Given this list of marker genes Ddit3, Scrib, Cenpi, Nek1, Haus3, Cdk18, Cep44, Tunar (NCBI Gene Id 69952), Mns1, Trim21, Cenph, Nbn, Vps72, Sgo2a, Ccdc15, Usp44, Camk2d (NCBI Gene Id 77170), Ppm1g, Foxe3, Mdm4, Zfp830, Ppp2r1a, Gadd45b, Ufl1, Ect2, Rpl10l, H2-M3, Senp2, Prkce, Morc2b, Jund, Prkaca, Ednra, Pole (polymerase (DNA directed), epsilon), Gigyf2 (NCBI Gene Id 98689), Mtcl1, Map3k7, Esco2, Ttk, Tuba3a, Anln, Six3, Gm21294, Gm5934, Myog (myogenin), Trp53, Rab11a, Msh4, Akt1, Exoc7, Mrgprb1 (MAS-related GPR, member B1), Nr4a1, Dynlt3, Haspin, Hmga2, Septin3, Cc2d1a, Kif14, Smc2, Stard9, Rrs1, Baz1b, Plrg1 (NCBI Gene Id 99527), Usp9x, Mnd1, Fbxo43, Dna2, Hsf2bp, Brd8, Bop1, Nrde2, Ccnd1, Rprd1b, Taf6, Prmt2, Aatf, Cdkn1c, Exoc6, Jade3, Taok1, Mir744, Zfp503, Btbd18, Rad54l, Katnb1, Bmp7, Ino80d, Phf10, Rhoc (NCBI Gene Id 99594), Lzts2, Mapre1, Egfr, Ywhae, Bmp4, Wee2, Pcnt, Dctn2, Cenpt, Mir124a-3, Mad2l1bp, Brdt, Ints7, Iqgap1, Pms2, D1Pas1, Hes1, Fbxo7, Tcf3, Anapc2, Gm29866, H1f8, Apex1, Prr11, Brd7, Zbed3, Svil, Ets1, Ncapg2, Rcc2, Usp8, Kifc5b, Zzz3, Hexim2, Ccpg1, Eif2ak4, Lsm14b, Nf2, Prap1, Prpf19, Dgkz, Nde1, Htt, Vash1, Pmf1, Myo19, Eme1, Ehmt2, Knstrn, Zwint, Mir26a-2, Hormad1, Npat, M1ap, Lfng (LFNG O-fucosylpeptide 3-beta-N-acetylglucosaminyltransferase), Zfp365, Son, Tubgcp4, Gm21760, Cenpk, Gm1993, Per2, Cep250, Gper1, Prox1, Rad51c, Cetn2, Hfm1 (NCBI Gene Id 381663), Hmgb1, Nek9, Cdk3, Bex6, Foxa1, Meig1, Fosl1, Zic1, Usp2, Ccdc42, Pdgfrb, Chmp1b2, Champ1, Dscc1, Trp63, Tpra1, Crebbp, 1700028K03Rik, Tmem67, Khdrbs1, Trim75, Celf1, Cenpf, Haus2, Pnpt1, Stag1, Mcmbp, Pkp4, Kif20b (kinesin family member 20B), Ing5, Ins1, Cgref1, Gja1, Calm1, Ago4, Cep76, Cenpo, Shoc1, Kctd19, Xlr4b, Rpl23, Junb, Nuggc, Map9, Madd, Birc6, Asns, Gpr15lg, Dlg1, Dync1h1, Dr1, Rec114, Luzp1, Espl1, Cdc27, Nudt6, Cks1b, Cdc16, Cep85, Med1, Haus8, Calm3, Ube2a, Plk1, Cdk5rap1, Kifc1, Nubp1, Insm1, Il1b, Nup43, Pik3c3, Numa1, Cdc5lrt7, Pcna, Nanos3, Septin6, Zfp36l1, Nup37, Fzd9, Epgn, Cep131, Gm1140, Ccl12, Xrn1, Ccnb2, Jade1, Angel2, Pmp22, Cul9, Cdc42, Gm28576, Anapc7, Septin5, Dstn, Ccnd2, Aunip, Cul4a, Mtbp, Ccny, Birc7, Mir124a-1, Setdb2, Tmsb4x, Appl1, Nek7, E2f8, Brinp2, Top2a, Xlr5b, Gm20824, Psma8, Gli1, Kcnn4, Cdc5lrt4, Pkmyt1, Chek1 (NCBI Gene Id 97555), Fancm, Tpx2, Ckap2, Spin1, Myocd, Rbm7, Ccnjl, Wdhd1, Trim36, Foxg1, Bmp2, Ppp2r1b, Rbl1, Cdk8, Septin7, Ppp2r3d, Sdccag8, Slf1, Mzt1, Camk2g, Mcm6, Mir124a-2, Rrm2b, Gm20820, Syde1, Cdkn1a, Smoc2, Crnn, Zscan21, Ube2l3, Gins3, Gm5169, Gm5168, Actl6b, Myh10, Gen1, Misp, Azin1, Klf11, Cebpa, Gm28102, Cul4b, Rptor, Stxbp4, Chmp6, Setd2, Akap8, Inip, Mrnip, Sh3glb1, Klhl18 (kelch-like 18), Tnks, Eme2, Ercc1, Tesmin (NCBI Gene Id 17771), Hpgd, Ino80b, Zic3, Spo11, Tiprl (TIP41, TOR signalling pathway regulator-like (S. cerevisiae)), Ube2i, Ctdsp1, Pard6a, Bccip, Camk2b, Yeats2 (YEATS domain containing 2), Gipc1, Usp29, Atm, Ercc4 (NCBI Gene Id 50505), Gm6121, Mdc1, Tcf19, 1700013H16Rik, Ccng1, Trrap, Cdk15, Haus5, Kif4, Slx4, Cenpa, Mta3, Zfp318, Csnk2a1, Stambp, Smarcad1, Arid2, Ush1c, Nr4a3, Chmp3, Cdc5lrt6, Cdca5 (cell division cycle associated 5), Mcrs1, Mir26a-1, Nup62, Calm2, Llgl2, Unc119, Ezh2, Ofd1, Prpf40a, Nop53, Nr2f2, Afg2b, Evi2b (ecotropic viral integration site 2b), Bmyc, Upf1, Cks1brt, Mrgbp, Ppm1d, Pttg1, Foxk1, Ncapg, Rps3, Brox, Mbtd1, Hjurp, Tas2r102, Eif4g1, Nasp, Sfrp1 (secreted frizzled-related protein 1), Nr2e1, Mybl1, Anxa1, Ube2s, Exoc4, Ccdc61, Ska1, Ccnb1, Akap8l, Azi2, Phf13, Ptprv, Mlf1, Chmp7, Xlr5a, Rprm, Dot1l, Brca1 (NCBI Gene Id 12189), Kdm8, Setmar, Sycp3 (synaptonemal complex protein 3), Fgf10, Rhou, Ccnb1-ps, Tert (telomerase reverse transcriptase), Mdm1, Ctdsp2, Ankrd53 (ankyrin repeat domain 53), Drd3, Stox1, Ankrd17, Septin2, Tubal3, Kiz, Wnk1, Tubb3, Ube2srt, Hyal1, Ckap5, Usp50, Pabir1, Stag2, Cdc26, Rad23a, Smarcc1, Ccno, Cdc5lrt1, Dynlt1b, Pdcd6ip, Utp14b, Bcl2l1, Yy1, Rtkn, Zfyve26, Ptprk, Septin14, Pds5a, Arid1a, Spc24, Fhad1, Psmd10, Kif20a, Lig1, Exoc6b, Ptprc, Ensa, Tuba1b, Bag6, Crocc, Abraxas2, Pkn2, Gm20870, Gm5935, Cdkl1, Dmrtc2, Sox2, Ppp2ca, Ppp2r5c, Tubb4b, Tbx1, Cenpu, Pbx1, Btrc, Tti1, Hepacam, Ccdc57, Xpo1, Uba3, Grb14, Chmp4c, Pnma5, Pogz, Clspn, Dtx3l, Sox9, Rec8, Phgdh, Hacd1, Wfs1, Sirt7 (sirtuin 7), Insm2, Kif18b, Rad17, Actr3, Cep120, Ilkap, Usp33, Ilk, Tex11, Brinp1, Gm2030, Rpl17, Cav2, Xlr5c, Wnt10b, Chmp5, Bin1, Brme1, Aspm, Mapk8, Ppp2r5d, Fsd1, Chmp4b (NCBI Gene Id 96954), Mok, Tsc22d2, Bax, Poc5, Bcr, Tfap4, Aicda, Pias1 (protein inhibitor of activated STAT 1), Xlr4a (NCBI Gene Id 630479), Rhno1, Slx, Vps4a, Nek6, Pafah1b1, Fbxo5, Inppl1, Ctdp1, Parp9, Znhit1, D7Ertd443e, Nfia, Fam83d, Ccar2, Nherf1, Stx2, Lipa, Stk38, Naa50, Rpa2, Tbce, Rnf2, Gm773, Tubb2a, Rps6kb1, Dlgap5, Igf2, Spdya, Cenpm, Yeats4, Zfp36l2, Cep192, Ccnh, Riok2, Tbcd, Arhgap33os, Tsc1, Piwil2, Dmrt1, Cdk13, Ctcf, Gem, Smarca2, Srpk2, Myh9, Aaas, Terb2, Pkhd1, Mau2, Ppp2r2d, Ciao2b, Stag3, Tex12, Pim2, Septin10, Map1s, Wdr90, Septin9, Efhc1, Adcyap1, Ncaph2, Ticrr, Sphk1, Klhl21, Nuf2, Fam110a, Boll, Ccne1, Cenpx, Hdac8, Lats2, Mbtps2, Zfy2, Itgb3bp, Mcm3, Rps6ka2, Smc6 (NCBI Gene Id 67241), Tom1l1, Cdc5lrt10, Sass6, Alox8, Tle6 (NCBI Gene Id 69799), Brcc3dc, Pds5b, Morf4l1, Mis12, Ankle2, 4933427D14Rik (RIKEN cDNA 4933427D14 gene), Obsl1, Gmnc, Fgf8, Sdcbp, Kank2, Prdm11, Cdk16, Birc3, Hus1, Zfp369, Cntln, Zw10, Xlr3a, Mapk12, Nek11, Btc, Nup214, Ccp110, Septin8, Nppc, Flna, Rmi2, Cdc23, Pibf1, H2ax, Tppp, Rad18, Tm4sf5, Sra1, Rnaseh2b, Gm21117, Edn3, Tubb2b, Nek2, Cdk6, Cdkl4, Suv39h1, Abcb1b, Nupr1, Septin12, Rps27l, Slxl1, Fbxl7, Ska2, Prpf4b, Ccnf, Dtl, Arl8b, Sgsm3, Cdc14a (CDC14 cell division cycle 14A), Gm4297, Incenp, Abcb1a, Lgmn, Il1a, Il10, Gm2012, E2f6, Bid, Igf1, Anapc1, Pten, Hspa1a, Gm7958, Btg3, Spry2, Slc26a8, Haus7, Mapk1ip1, Ereg, Pstpip1, Prc1, Ripor2 (RHO family interacting cell polarization regulator 2), Bcl2, Tal1, Arhgef2, Wiz, Ccna2, Cops5, Trappc12, Bub1, Tpd52l1, Ptgs2, Kash5, Sirt2, Ddx4, Nudc, Pagr1a, Parp3, E2f1, Rrm2, Clgn, Xiap, 4930447C04Rik, 3830403N18Rik, Nlrp5, Pld6, Rab11fip3, Brcc3 (NCBI Gene Id 210766), Uvrag, Pcm1, Pggt1b, Sgo1, Spry1, Cltc, Tlk1, Iqgap2, Kat2b, Cdk4, Aurkc, Golga2, Gpr3, Atxn10, Plk4, Osm, Top3a, Gpsm1, Fzr1, Arhgef10, Axin2, Cdk5rap2, Smarcd1, Smpd3, Uhrf1, Stil, AY074887, Diaph3, Vps4b, Camk2a, Errfi1, Rad51d, Dact1, Gm29276, Dctn6, Bcl2l11 (NCBI Gene Id 76339), Iqgap3, Slc25a31, Cdkn1b, Kat7, Dctn3, Ovol1, Gnb1l, Cdc45, Ubb, Tas2r121, Mybl2, Trip13, Eif4e (NCBI Gene Id 668879), Spart, Ubr2, Chmp2b, Pola1, Tubd1, Rhob, Hoxa13 (NCBI Gene Id 15398), Git1, Chmp1b, Tex15, Ube2b, Ndc80, Trim71, Cdc6 (cell division cycle 6), Ncapd3, Mir26b, Ezr, Psme1, Bora, Lrp6, E2f4, Cdk11b, Dab2ip, Bcl7c (NCBI Gene Id 233901), Mnat1, Nsl1, Fbxw11, Bnip2, Brd4, Tas1r2, Mei4, E4f1, Stk11, Xlr3c (NCBI Gene Id 768249), Adam17, Kif23, Rps15a, Birc2, Mtmr4, Ccni, Zfyve19, Meioc, Hspa2, Fbxw7, Btn2a2, Sfn, Sirt1, Meikin, Cenpe, Ptpn11, Tubb6, Poc1a, Ccnq, Prkca, Psmd13, Calr, Zfp541, Nfix, Anxa11, Plk2, Rad50, Cntrob, Id2, Skil, Cdca8, Pebp1, Cdkl3, Anapc15, Usp16, Hnrnpu, Dicer1, Mki67, Plk5, Rnf212b, Exoc5, Ctbp1, Ccnl1, Ciao2a, Tubg2, Slc16a1, Mael, Ska3, Cdc7, Tuba1a, Dnm2, Rpa1, Tex14, Fgf2, Chordc1, Limk2, Cdca2, Rgcc, Ino80e, E2f2, Esco1, Pdpn, Smc1b, Cdc73, Gm28919 (predicted gene 28919), Exoc8, Nsun2, Pum1, Tubb5, Fhl1, Pcid2, Ing2, Rttn, Cenatac, Tex19.2, Rxfp3, Ecd, Msh2, Cables2, Cep63, Egf, Brsk1 (BR serine/threonine kinase 1), Cdk17, Cdk9, Prdm5, Cry1, Mcidas, Birc5, Anapc5, Atr, Recql4 (NCBI Gene Id 79456), Trp53i13, Snx33, Tubb4a, Bak1, Usp19, Top3b, Taok3, Ccnd3, Ccng2, Orc1, Ndc1, Nanos2, Ppp3ca, Zbtb17, Exd1, Dpf3, Cpsf3, Mdm2, Ddr2, Ccnb3, Adamts1, Fem1b, Nme6, Tubgcp2, Hdac3, Smarcb1, Cdk2, Pard6b, Paf1, Sin3a, Mapk15, Paxip1, Tom1l2, Exoc2, Ran, Dbf4, Tgfb2, Mbtps1, Cdk5r1, Prkdc, Llgl1, Prickle1, Cks2, Pkd1, Fgfr3, Gas2, Pax6, Mtcl2, Bmal1, Filip1l, Gm29554, Csnk1d, Rmi1, Spice1, Aven, Eml3, Tacc1, Smarcc2, Lif, Ier3, Stmn1, Npm2, Rock1, Chmp1a, Pou4f1, Nabp2, Rad21, Ctnnb1, Sun1, Tbrg1, Shb, Rnf167, Rps6, Fbxo30, Smarca4, Mepce, Pkia, Casp3, Dapk3 (death-associated protein kinase 3), Cacnb4, Cdt1, Cspp1, Hspa8, Kat2a, Cul7, Gata4, Romo1, Mus81, Epc2, Mcm5, Nek10, Cep152, Actr8, Cts7, Ttl (NCBI Gene Id 99091), Npm1, Mcm2, Cep295nl, Enkd1, Tubgcp5, Pclaf, Slf2, Mfn2, Ntmt1, Clock, Snx9, Sin3b, Tdrd12, Kif2a, Cdk14, Fkbp6, Ubd, Tsg101, Msx1, Sik1, Spast, Ube2c, Adarb1, Cpeb1, Dcun1d3, Meis2, Meaf6, Gnai1, Jade2, Syf2, Wdr6, Mecom, Cdk20, Ccnk, Thap1, Poldip2, Ifnz, Ascl1, Uhrf2, Iho1 (NCBI Gene Id 434438), Dyrk3, Ddias, Rnf112, Skp2, Lin9, Rangrf, Appl2, Racgap1, Catsperz, Sh2b1, Fgfr2, Rbl2, Ciao1 (NCBI Gene Id 99343), Gins1, Rrm1, Wrn, Ythdf2, Cetn1, Ccdc8, Hus1b, Npr2, Spag5, Trnp1, Ercc2, Ing4, Actr5, Poc1b, Shcbp1l, Pik3r4, Nek4, Kat5, Cdc20, Trp73, Khdc3, Ins2, Cdk2ap2, Fen1, Morf4l2, Gm20911, Rae1, Zwilch, Susd2, Lmna, Gm21996, Nat10, Daxx, Ino80, Kif18a, Actb, Cyp27b1, Snhg15, Cep55, Deup1 (NCBI Gene Id 234964), Babam2, Ccnj, Ptch1, Plk3 (NCBI Gene Id 12795), Hsf5, Taf2, Donson, Cables1, Smc1a, Plaat3, Ube2u, Xrcc2, Foxj2, Exoc1, Ank3, Haus6, Chfr, Stk35, Ccna1, Rcc1, Seh1l, Pdxp, Pde4dip, Lep, Map3k11, Klf4, Pin1, Tuba4a, Ankk1, Msh5, Rtel1 (regulator of telomere elongation helicase 1), Itgb1bp2, Ywhah, Pdgfb, Fmn2, Ecrg4, Ncor1, Btg4, Cenpn, Uhmk1, Banf1, Rny1, Sugt1, Cirbp, Gm28510, Miip, Meiosin, Cacul1, Tfdp2, Mlh1, Kif2c, Rab35, Plpp2, Foxj3, Cenpw, C2cd3, Cdc5lrt8, Brinp3 (NCBI Gene Id 215378), Sfpq, Fzd3, Ruvbl2, Esx1, Hecw2, Rara, Rhoa, Hhex, Neurog1, Cdc5l, Sgo2b, Terf1, Tbx2, Anapc15-ps, Tas2r124, Arpp19, Klhl13, Washc1, Bub3 (NCBI Gene Id 97366), Edn1, Gm20817, Csnk2a2, Tnfaip3, Sptbn1, Gm20843, Gm10230, Fbxw5, Tent5b, Strada, Terb1, Tex19.1, Tgfa, Washc5, Kcnh5, Tube1, Dyrk1a, Ccne2, Arl3, Men1 (multiple endocrine neoplasia 1, NCBI Gene Id 17283), Ccnc, Gbf1, Dusp3, Ppp2r5b, Mcph1, Ccsap, Wdr12, Spdye4a, Tubb1, Cdkl5, Piwil4, Brca2, Aurka, Kif2b, Blm, Smarce1, Hinfp, Rad9b, Atf2, Prkcq, Iffo1, Fap, Rgs14, Usp37, Mn1, Nkx3-1, Mapk14, Tdrd9, Cenpv, Rdx, Myo16, Cdk10, Firrm, Topbp1, Ppp1r10, Trex1, Pinx1, Cdc5lrt9, Ccnb1ip1, Nipbl, Zbtb49, Rack1, Ccnl2, Kif3a, Knl1, Haus1, Ercc3, Cdk1, Gpnmb, Psrc1, Kat14, Tubgcp6, Cit (NCBI Gene Id 320895), Foxo4, Anapc11, Heca, Uxt, Dach1, Usp51, Smc5, Abl1, Wee1 (WEE 1 homolog 1 (S. pombe)), Sox15, Larp7, Rsph1, Cul3, Zfp207, Fanca, Drg1, Fbxo4, Timeless, Cdk12, Cdk19, Grk5, Tgm1, Ankrd31, Stat5a, Asah2 (N-acylsphingosine amidohydrolase 2), Gsk3b, Cdkn2c, Septin4, Brsk2, Cep72, Rbbp8, Eif4ebp1, Cenpl, Ncapd2, Snd1, Pla2r1, Acvr1b, Wasl, Lsm14a, Naa60, Psme2, Gadd45g, Rb1, Lrp5, Rnf212, Clasp1, Lemd3, Dmc1, Eml4, Trim35, Apc, Usp17le, Wnt16, Cetn4, Sycp1, Anp32b, Phb2, Atad5, Eif4g3, Xrcc3, Mad1l1, Cep295, Chmp2a, Usp26, Suv39h2, Acvr1, Ppp2cb, Kif3b (kinesin family member 3B), Fbxl15, Kif15 (NCBI Gene Id 73146), Slfn1, Ddx11, Smc4, Kif22, Spdl1 (spindle apparatus coiled-coil protein 1), Tcim, Ubxn2b, Gm14525, Klhl22, Exo1, Cyld, Serpine1, Cep126, Crlf3, Ppp1r7, Sun2, Ncaph, Drd2, BC034090, Tbx3, Mybbp1a, Dusp1, Nsfl1c (NSFL1 (p97) cofactor (p47)), Nras, Foxn3, Prdm9, Rbm38, Anapc4, Tfpt, Ep400, Xlr, Trp53bp1, Ppp1r12a, Dbx2, Rnf4, Sgf29, Lcmt1, Atf5, Hnf4a, Foxm1, Gdpd5, Xlr4c, Rbm14 (NCBI Gene Id 71771), Fancd2, Ttyh1, Zfp655, Mettl3, Atrx, Tmod3, Met, Id4 (inhibitor of DNA binding 4), Fam107a, Stat5b, Uchl5, Mos, Tada2a, Jun, Ik, Apbb1, Plscr1, Mir214, Mlh3, Pde3a, Nfib, Alms1 (NCBI Gene Id 381791), Inhba, Dpf2, BC005624, Mcm7, Afap1l2, Apbb3, Mir16-1, Ttc28, Mblac1, Ctdspl, Orc4, Nudt16 (nudix hydrolase 16), Myc, Prkacb, Nfatc1, Map10, Bcl7a, Chtf18, Redic1, Tk1, Cdc25c, Creb3l1, Stk33, Lef1, Ing3, Vcp, Rassf1, Dctn1, Ndel1, Marf1 (NCBI Gene Id 98041), Ccdc69, Cdkn2d, Lsm11, Kif13a (kinesin family member 13A, NCBI Gene Id 328239), Ndp, Pdik1l, Nfrkb, Ranbp1 (RAN binding protein 1), Ankfn1, Smim22, Mir664, Rfwd3, Hsf1, Rab11fip4, Syce3, Klhdc8b, Rint1, Mme, Insr, Srpk1 (NCBI Gene Id 20815), Gata6, Reep3, Lyn, Rad51ap1, Gm21865, Spire1, Pbrm1, Cdkn3, Entr1, Mre11a, Tfdp1, Fignl1, Mms19, Ddb1, Gjc2, Kif11 (NCBI Gene Id 16587), Becn1, Psmc3ip, Mad2l1, Mbip, Flt3l, E2f3, Nusap1, Bcas2, Capn3, Cep135, Cdkl2, Cdkn2a, Chd3, Smarcd2, Tacc3, Apbb2, Actr2, Macroh2a1, Krtap21-1, Alkbh4, Trim37, Nes, Septin1, Majin, Hepacam2, Ttll12 (NCBI Gene Id 223723), Cgrrf1, Psme3, Piwil1, Lats1, Ppp1r35, Plcg2, Senp6, Cdk5rap3, Ino80c, BC004004, Fbxo31, Cenpq, Ruvbl1, Cd28, Gmnn, Slc6a4, Meiob, Phf8, Rpa3, Sstr5, Mcmdc2, Tardbp, Asz1, Lsm10, Tdrkh, Lin37, Haus4, Tbx20, Ddx3x, Foxc1, Tnf, Ints13, Ctc1 (CTS telomere maintenance complex component 1), Cdc14b, Xpc, Hormad2, Dis3l2, Map4, Sac3d1, Tpr, Rpl24, Ambra1, Mcm4, Nae1, Ppp2r2a, Trim32, Mei1, Mnt, Smarca5, Mis18a, Ist1, Pard6g, Gm20736, Klhdc3, Nabp1, Vax2os, Cdc25b, Dsn1, Tubg1, Ercc6, Zfp703, Pml, Hspa1b, Gm28870, Taf10, Abraxas1, Eps8, Csf1r, Gata3, Bcl7b, Psmg2, Syce2, Ankle1, Usp28, Pkp3, Wapl, Brip1, Plcb1, Arl2, Cdk5, Bbs4, Spata22, Gpsm2, Irf1, Tuba8, Tlk2, Pes1, Esr1 (NCBI Gene Id 13982), Atrip, Phip, Tacc2, Gadd45a, Rtf2, Mbd4, E2f5, Pum2, Tipin, Spire2, Hsp90ab1, Cib1, Ppp6c, Runx3, Myb, Cdc5lrt5, Eml1, Aif1, Gas1 (growth arrest specific 1), Cxcr5, App, Trim39 (tripartite motif-containing 39), Ptpa, Zmpste24, Top6bl, Ahctf1, Smarcd3 (NCBI Gene Id 78383), Gtf2b, Cdc25a, Wrap73, Inha, Zcwpw1, Prr19, Kcna5, Gm10488, Wdr5, Nle1, Tdrd1 (NCBI Gene Id 83561), Naa10, Dnmt3l, L3mbtl1, Timp2, Top2b, Uimc1, Wac, Etaa1, Exoc3, Chtf8, Nudt15 (nudix hydrolase 15), Usp47, Arf6, Dazl, Bex4, Smc3, Ooep, Itgb1, Cep97, Bard1, Recql5, Bub1b, Nfe2l1, Sapcd2, Wdr62, Rad1, Galnt3, Fnta, Wdr76, Zpr1, Rbm46, Msx2, Arl8a, Clasp2, Stra8, Tuba1c (NCBI Gene Id 22146), Slc25a5 (NCBI Gene Id 11740), Cfl1, Cited2, Lmnb1, Ovol2, Syce1l, Kmt2e, Rad54b, Map3k20, Sbds, Ppp1r13b, Cyp26b1, Epm2a, Tgfb1, Nin, Syce1, Sycp2, Top1, Rad9a, Bend2, Igf1r, Mettl13, Inca1, Phactr4, Gpr132, Dmap1, Rny3, Epc1 (enhancer of polycomb homolog 1), Gm28961, Cenpc1, Txlng, Actl6a, Aurkb, Snx18, Fntb, Tjp3, Cntd1, Jtb, Dync1li1, Wnt5a, Sipa1, Mark4, Gm21627, Cdk7, Septin11, Rrp8, Cyp1a1 (cytochrome P450, family 1, subfamily a, polypeptide 1), Cdkn2b, Gm21858, Nedd1, Fes, Ptpn6, Chek2, Kpnb1, Pim3, Ssx2ip, Ints3, Tsc2, Bap1, Rad51b, Myh14, Pkd2, Wnt4, Atf6b, Tubgcp3, Nupr2, Rad51, Ccdc66, Prcc, Siah1a, Gm20890, Dpf1, Mapre2, Sde2, Nanog, Usp22, Mastl (microtubule associated serine/threonine kinase-like), Nr2c2, Mitd1, Spc25, Cep68, Tada3, Fgfr1, E2f7, Pim1 (NCBI Gene Id 18712), Znrf4, Rock2, Taok2, Ptpn3, Mov10l1, Rad21l, Kntc1, Rspo1, Ccn2, Nsmce2, Dcaf13 (NCBI Gene Id 223499), Ythdc2, Zc3h12d, Cenpp, Reep4, Hras, Xlr3b, Mapre3, Ube2e2, Oip5, Plec, Cenpj, Gm21095, Atp2b4, Stat3, Klhl9, Cenps, Babam1, Arf1, here is a description of the gene set: Mouse Gene Set: GOBP_CELL_CYCLE The progression of biochemical and morphological phases and events that occur in a cell during successive cell replication or nuclear replication events. Canonically, the cell cycle comprises the replication and segregation of genetic material followed by the division of the cell, but in endocycles or syncytial cells nuclear replication or nuclear division may not be followed by cell division. studied in species Mus musculus